The following is a description of a gene set: Mouse Gene Set: GOBP_POSITIVE_REGULATION_OF_MHC_CLASS_I_BIOSYNTHETIC_PROCESS species: Mus musculus Any process that activates or increases the frequency, rate or extent of the chemical reactions and pathways resulting in the formation of MHC class I., and this is the list of marker genes: Ciita, Hsph1 (heat shock 105kDa/110kDa protein 1), Nlrp12, Il33, Nlrc5